The following is a description of a gene set: studied in species Homo sapiens Transcription regulation during the cell cycle is crucial for ensuring genes are expressed at the right time and in the correct amounts, coordinating key processes like DNA replication, mitosis, and cell division. In our study, Human Gene Set: PULVER_FOREY_PERTURB_ATTRITION_S Genes whose depletion leads to accumulation of cells in S (pVal < 0.05) in K562 Repogle et al., 2022 reanalyzed with Velocycle from Lederer et al., 2024, and this is the list of marker genes: CLN6, PLA2G15, TALDO1, HS6ST1, EIF3H, TSPAN3, RRAGA, CSRNP1, E2F3, ARMC10, MRPS16, GPN1, ZNF480, FLYWCH1, SDF2, MFSD6, ZBED4, IARS2, C11orf24, ETHE1, TMED5, MED19 (mediator complex subunit 19), COX15, ANKS1A, ASMTL, ZNF658, GDI1, TMEM208, DENND2D, ITPR2, PPIL4, GLE1, PEX6, PSKH1, PARS2, DCPS, MBTPS2, TMEM123, SRSF7, ZNF470, SALL4, ARAF (A-Raf proto-oncogene, serine/threonine kinase), PMPCA, ATP5MC1, A1BG, CALM1, RNF40, KLF10, NOP58, GALK2, SEC11A, ARHGAP22 (Rho GTPase activating protein 22), DLX4, ERGIC2, XPO1, AP5Z1, BBLN, DEPDC7, EDC4, COQ5, UBAP1, PRPSAP1, POGZ, RHBDD1, NPHP4, ERN1, MTNAP1, SLC35B1, EHF, PHOX2A (NCBI Gene Id 8064), ELOB, SSRP1, RARS1, KATNBL1, RNF220, NKAP, PRDX3, DBR1, INTS7, HMGN2, RTCB, AUP1, DHRS3, TTI1, KAT8, ELAC2, BBS7, JPT2, PGS1, IFT25, ZNF821, GABRG3, ZNF568, GP1BB, SMCHD1, CD320, DLX5, GATA6, CHORDC1, SETD7, HOXD11, GBF1, GNPTAB, KLF1, DHX30, DYNC1H1, SCRIB, C16orf87, CDKAL1, ATR, ARIH2, SMC6, TRNT1, EIF2B5, DIS3L2, ESAM, TFDP1, DONSON, DST, CD164, SRPRB (NCBI Gene Id 58477), OLFML3, DOCK6, CPOX, SSBP2, MRPL17, RILP, RC3H2, FRAT2, CENPV, PUM2, ASAH2B, C12orf43, CREB3, PSTPIP2, ZNF383, IARS1, FANCM, HERPUD1, ESYT1, CENPC, GINS4, LSM3, NMT2, DENR, BNIP1, MCU, CHCHD3, ARHGEF9, MTOR, ZIC3, ZUP1, SRP19, RBM10, GEMIN5, TRIM21, SMC1A, H2AC25, TBCB, B4GALT1, MOB1B, DPP8, UBA2, CDC42SE2, ATRIP, GFM1, ZNF493, MORF4L1, CDC6, ZNF853, METTL2B, HAPSTR1, EIF2B2, PFDN2, NUP54, CORO7, ADPGK, SDF4, ZDHHC3, ANHX, RUNX1, FBXW7, PARP1, FAF2, ZNF18 (zinc finger protein 18), PARP14, PLCB3, IRF1, LYRM2, PPP1R16B, ATP5F1A, POU6F2, NKX2-1, MEX3D, DNAJB11, UCK1, GPN3, EIF2S3, FMR1, DDX28, PMPCB, MXI1, SP100, RHOQ, XIAP, CRLF3, RGPD6, CDCA5, TOR1A, H4C14, CENPT, ZNF311, CRBN, TCF25, PRCC, SCLT1, VGF, DCAF10, LRRC37A3, CHMP3, GRAP2, DNAJC3, PTK2B, LSM2, ZNF577, THEM6, NR1D2 (NCBI Gene Id 9975), BGLAP, ANKLE2, SPECC1L, ERF, SIRT7, DGKD, NUDT22, BARX1, NAMPT, GFPT1, PCYT1A, FBXL12, TULP1, APPBP2, MMACHC, UXT, PICALM, ESYT2, DNAJC7, ZNF319, PDXDC1, NBAS, HAX1, RBM6, RBCK1, GSE1, DNM1L, PLEKHF2, PDE12, ZNF850, MICAL1, IPO13, LMAN1, CERS6, RBBP7, MRPS26, TIMM13, ZNHIT6, GTF3C3, GK5, OXA1L, NDRG3, ZKSCAN1, INTS9, ANKRD13C, SLC39A14, FNDC3A, DAD1, ZNF888, FZD5, MCAM, ZNF555, SCYL1, TBX4, EIF5A, INHBE, ADO, SEC22B, GAB2, UBN1, NAA25, EVX2, SUPT6H, DECR1, KIF15, LLPH, ARL3, RILPL2, DEAF1, PDHB, HK1, KARS1, GPKOW, PIGX, MNAT1, DNAJC19, DPM2, METTL1, FRYL, WIPF1, CT45A5, RETSAT, CMPK2, EIF3F, TRAPPC11, PSMB7, CSE1L, NEK2, ECHDC3, CWC15, ACIN1, GTF2H1, ATOH7, GLB1L2, POLR2C, SUCO, FBXW9, DDX5 (DEAD-box helicase 5), MAST4, ETV4, MLXIP, COPA, BICD1, ALG6, EPS15L1, ITSN2, ISYNA1, CWF19L2, PHF5A, UBE3C, CDC45, POLG, PI4KB, DFFB, MUTYH, DCTN3, GTPBP6, ARRB1, CLP1, INTU, FNDC4, ACTR10, RPTOR, CHID1, CLTC, CCNL1, CYP3A5, BLOC1S1, ADAM10, NLRP2, RAP1GDS1, JUN, RUVBL1, PKMYT1, COPS9, USP32, RBM39, MINPP1, INTS11 (NCBI Gene Id 84139), STAP2, SLC25A10, PSMC1, SPAG5, METTL22, NFATC4, DHDDS, TTI2, PPP3CA, ZBTB1, ODR4, CCHCR1, SART3, COX6B1, ST6GALNAC4, ABHD16A, NUDT21, RIPK2, VARS2, EIF2B4, PEA15, BAG5, TMEM19 (transmembrane protein 19), PNPLA4, ACADSB, CWC27, FERMT2, ACLY, CD99, DARS1, DOHH, PRDM4, UBXN8, TRRAP, MAFK, XPO7, ARL16, GINM1, MIOS, ALG12, LSM5, SEC61G, HAPLN2, EEF1A2, SNX12, CITED2, ZNF479, UFC1, COASY, FOXQ1, EIF5A2, MAD2L1, TSPAN13, CLN8, SGSM2, NHEJ1, PKIG, FBXO45, ANKRD46, EPC1, CENPK, TCF7, ABCA7, BHLHE40, ATP5MG, NELFE, TTC17, NFYB, LEUTX, MRPL3, BATF2, GATAD1, PFKFB2, DHCR7, CXXC1, NME1, DDX20, NIPSNAP1, HSD17B8, ATP5F1D, CYFIP1, DUS2, LONP1, SIX5, HIP1R, PIWIL4, MED12, MAFB, PROS1, C6orf62, SMAD5, USP14, HSD17B10, INTS2, ODF2, ZNF296, CUL1, QSER1, SNRPG, SF3B4, SMYD2, PEX19, ZNF354C, VCL, SRP68, UBP1, SERINC3, SSNA1, PHPT1, DHX15, CCDC12, COPE, PSMD7, DIAPH1, ZNF669, PSTK, MCM3, GTF2H3, FAM241B, COG8, PGAP2, GDE1, BOLA1, LSM6, FOXH1, PAFAH1B3, TIMM23B, RETREG2, ACVR2B, TMEM43, MRI1, INTS8, SRRM1, SIAH1, CCDC107, POLR2I, CAPNS1, SRP9, CAP1, AKAP13, EPS15, DENND4A, CKB (NCBI Gene Id 96634), H3C1, DDOST, SPTAN1, GPI, FAM32A, S100A13, CD52, KHDC1, FARSA, ZFAT, CSNK1G3, BCAR1, PSMD4, PIGU, MAP1B, CAST, MLST8, DHRS12, CYTH1 (cytohesin 1), GLRX5, DMRTA2, AGGF1, UBE4A, CEP44, U2SURP, TRUB2, HSPA1B, PAN2, CDK5RAP3, GTF3C4, ZCRB1, DDX46, SDE2, NAPG, INTS1, SMC4, HAUS7, VARS1, H1-10, PIGM, HMGB3, BCAT1, CDC14A, EIF2B1, COX14, BAX, GEMIN4, MRPS17, RPN1, MTR, BTN3A2, HOOK2, MTREX, DCTN4, SCAF11, LHX9, MRPL13, ESS2 (NCBI Gene Id 8220), NDUFA3, SLC2A13, SIX6, KPNA4, YEATS4, TOPBP1, TAGLN2, MRPL36, EXO1, ZNF671, ROMO1, CTPS2, NDFIP1, BLZF1, JDP2, MEGF8, INTS5, TBCA, NGLY1, HNF1A, MRPS15, BCL7A, XK, NADK2, AAK1, WDR77, WASL, CHMP6, ZBTB43, PKP3, ZNF789, CDK2, NKIRAS2, DIS3L, GLUD1, AGPS, TLK2, ZNF26, F11R, DMC1, RPAP2, ISCA2, YBX2, ARPC5L, DNAJA3, MRPS11, H4C8, GPRIN1, PFKM, TUBGCP4, SUPT5H (SPT5 homolog, DSIF elongation factor subunit), ARHGEF18, PHAF1, CCM2, DOK2, FMNL1, ZBTB5 (NCBI Gene Id 9925), DNAJA1, MAPK1IP1L, DSCR4, THAP10, CHCHD4, ZFP57, PUF60, PCM1, CTR9, GPD2, INTS3, TOMM22, SCFD1, CDC42EP4, PCYT2, NDUFS6, HPF1, IRAK4, NSL1, SORD, ANKRD26, ZNF808, NAA20, CCDC25, MRPL9, HIPK1, AUNIP, SAE1, MRC2, TRAF3IP2, COQ10A, EPRS1, PHB1, ZDHHC8, SSH2, HSPA9, AIFM1, IPO8, TNPO3, PEX16, ASB3, TCF15, OFD1, KANSL2, FKBP4, CHEK2, PTGES3 (NCBI Gene Id 10728), RNASEH1, DECR2, CHSY1 (chondroitin sulfate synthase 1), CISH, IGBP1